Given this list of marker genes IFT56, PKHD1, NPHP3, FCGR2A, CFTR, LBR, POU2AF1, STX5, ABCB4, DCDC2 (doublecortin domain containing 2), IL12A, TNPO3, TNFSF15, TGFB1, KRT18, IL12RB1, WDR35, SPIB, MMEL1, IRF5, here is a description of the gene set: Human Gene Set: HP_BILIARY_CIRRHOSIS Biliary cirrhosis Progressive destruction of the small-to-medium bile ducts of the intrahepatic biliary tree, which leads to progressive cholestasis and often end-stage liver disease. studied in species Homo sapiens